Given this list of marker genes Tbl1xr1, Aif1l, Scamp3, Cdc27, Txndc16, Arl8b, Tet1, Acan, Mbtps2, Ctcf, Efcc1, Ankrd23, Lamp2, Slc7a12, Zfp953, Sumo2, Camta2, B3galt2, Fcmr, Ndst3, Rnf41, Rnase1, Plekho2, Asz1, Mucl2, Relch, Slc12a4, Kbtbd13, Chsy1, Fbxo24, Pde1c, Fbxw22, Chga, Tle1, Cd276, Krtap17-1, Alox12, Spire1, Hnrnpr, Ppih, Pate2, Flt4, here is a description of the gene set: Mouse Gene Set: MIR_344I studied in species Mus musculus from publication Chen Y, Wang X (PMID 31504780) Genes predicted to be targets of miRBase v22 microRNA mmu_miR_344i in miRDB v6.0 with MirTarget v4 prediction scores > 80 (high confidence targets).